Given this list of marker genes SERPINB7, FBXO31, GNS, CCL22, FAM219B, ANAPC2, GAREM1, POU4F1, CBR1, SRSF5, LIMD2, STIMATE (NCBI Gene Id 375346), DMC1 (NCBI Gene Id 11144), COBLL1, PRMT7, SRFBP1, TRPV1, ASNSD1, NDUFAF7, SH3TC2, COL17A1, PIP5KL1, TMEM260, PCDHA12 (NCBI Gene Id 56137), PDE7B (phosphodiesterase 7B), TXLNA, VAMP1, DGKH, MBD4, ARHGEF38, PEX10, SPG11, TMPRSS2, CACNA2D3, RPS3, NTS, AFAP1L1 (actin filament associated protein 1 like 1), TCERG1L, CD36, FAM170A, KATNB1, MISFA (mitochondrial sheath formation associated), ATP8B1, TAF7, CREB5, PAK2, COASY, ANAPC10 (NCBI Gene Id 25866), GPC5, APOD, SLC15A1, ASB5, ICE1, LSM10, NUDT12, LSM6, MTRES1, NSMAF, DRGX, ADORA3, MRPS16, MRPS30, RAB3C, SELENOF, KCTD6, CTBP1, CLCC1, BICD1, FAAP100, TBC1D21, CNTN3, KCNK13, PRICKLE3, GLRB, ARHGEF15, ZNF157, ZNF606, SYCP3, POLL, VPS39, DDR1, FAT3, DDX59, CAMK1D, DHH, VPS11, ZMYM2, PLA2G4A, SLC17A7, CCNB1IP1, ACTRT2, EVX1, PARVB, FBXO10, CCDC88A, MGA, SRCAP (NCBI Gene Id 10847), ACOX3, DNAAF8, COPB2, PHACTR4, RYR3, TNRC18, CYBB, PDGFD, ZBTB1, ZNF329, SPATC1L, AAGAB, RASA2, HDAC8, TIMM17B, ADAMTS19, BBS10, RFTN1, SYT16, PI4K2A, TRAPPC4, SNAI2, WDSUB1, GABRG1, PRPS2, ZNF354B, COPS3, FAM149B1, ANKRD22, SLC18B1, CHL1, ADAT1, MRO, GRM3, H2BC18, B3GALNT2, AKR1E2 (aldo-keto reductase family 1 member E2), ARHGAP29, SAPCD1, ACSM2A, DCAF4, DGKI, STAU2, F8, LRRC34 (NCBI Gene Id 151827), SF3B2, CDK5RAP1, CLUAP1, EIF4EBP2, SHCBP1L, BARHL2, ROBO3, GNB1L, UBTFL1, ZFP92, CHD1L, DERA, ADCK2, FAM43B, ARPIN, PPP1R7, NACAD, POLR2K, CLEC4A, FAM120AOS, GDAP1, IL27RA, C1orf53, FANCL, HSD17B10, HLA-DRB1, VSTM5 (V-set and transmembrane domain containing 5), PAN3, PRSS41, PPP4R3B, TAB3, ZCCHC4, TTC3, PLCD4, SUGP1, FUCA1, HSD17B6, FCER1A, ZCCHC18, FRRS1, PDHA2, STOX2, AP1B1, GJB5, MSI2, MLXIP, HORMAD2, MCM3AP, B4GALT6, NAPB, MFSD14A, MAIP1, CPSF7, RECQL5, AMACR, UBA3, PHAX, POLB, here is a description of the gene set: Human Gene Set: GSE8921_UNSTIM_0H_VS_TLR1_2_STIM_MONOCYTE_3H_UP studied in species Homo sapiens In innate immune responses, activation of Toll-like receptors (TLRs) triggers direct antimicrobial activity against intracellular bacteria, which in murine, but not human, monocytes and macrophages is mediated principally by nitric oxide. We report here that TLR activation of human macrophages up-regulated expression of the vitamin D receptor and the vitamin D-1-hydroxylase genes, leading to induction of the antimicrobial peptide cathelicidin and killing of intracellular Mycobacterium tuberculosis. We also observed that sera from African-American individuals, known to have increased susceptibility to tuberculosis, had low 25-hydroxyvitamin D and were inefficient in supporting cathelicidin messenger RNA induction. These data support a link between TLRs and vitamin D-mediated innate immunity and suggest that differences in ability of human populations to produce vitamin D may contribute to susceptibility to microbial infection. from publication Liu PT, Stenger S, Li H, Wenzel L, Tan BH, Krutzik SR, Ochoa MT, Schauber J, Wu K, Meinken C, Kamen DL, Wagner M, Bals R, Steinmeyer A, Zügel U, Gallo RL, Eisenberg D, Hewison M, Hollis BW, Adams JS, Bloom BR, Modlin RL (PMID 16497887) Genes up-regulated in monocytes: untreated versus M. tuberculosis 19 kDa lipopeptide (3h).